The following is a description of a gene set: Human Gene Set: HP_FINE_HAIR Fine hair Hair that is fine or thin to the touch. studied in species Homo sapiens, and this is the list of marker genes: LIG4, GJB6, RNU4ATAC, GJA1, DCAF17, TP63, CARS1, PYCR1, SUZ12, NSD1, EDARADD, TRIM8, TRPS1, KRT71, MED12 (mediator complex subunit 12), ALX4, MAP2K2, HPD, GNPTAB, IFT122, KRT25, EDAR, RMRP, WNT10A, SKIC3, DSG4, SUOX, IFT43, SPINK5, KRAS, HRAS, HECTD4, TINF2, PCNT, ABCD1, SLC7A7, ZFX, SIN3B (SIN3 transcription regulator family member B), LPAR6, BRF1, MAP2K1, KCTD1, CDSN, TRMT10A, GATAD2B, CTC1, SATB2, CDH3, GTPBP2, NBAS, TWIST2, PUM1, NAA10, KRT83, ALMS1, IKBKG, KRT74 (NCBI Gene Id 121391), COL3A1, EZH2, ERCC2, WDR35, DYM, SIN3A, EDA, CBL, WBP4, RAF1, CSTB, KRT81, OCRL, KRT86, DEAF1, SMAD4, RLIM, PIGL, LIPH, PPP1R15B, KAT6B, NSUN2, MSX1, ITGA3, SMARCAL1, BRAF